The following is a description of a gene set: Tristetraprolin (TTP, ZFP36) binds and destabilizes mRNA Mouse Gene Set: REACTOME_TRISTETRAPROLIN_TTP_ZFP36_BINDS_AND_DESTABILIZES_MRNA species: Mus musculus, and this is the list of marker genes: Exosc2, Ywhab, Dcp2, Xrn1, Dcp1a, Exosc4, Tnpo1, Exosc8, Exosc5, Exosc1, Dis3, Exosc3, Exosc6, Mapkapk2, Exosc9, Zfp36, Exosc7